Given this list of marker genes Serpinb9, Tmem43, Trim41, Ccl6, Lamp1, C1qb, Zp3r, Tnfrsf1b, H60b, Rab20, Defb5, Triml2 (tripartite motif family-like 2), Lrch4 (NCBI Gene Id 76977), Gm15441, Gimap5, Adam15, Klrc3, Ptger2, Ccdc186, Plaat3 (phospholipase A and acyltransferase 3), Defa37, Slc11a1, Ifit3, Nlrp3, Defa34, Il10ra, Mpo, Calm3, Ddit4, Usp27x, H2-Q7, Cdk6, Lrrc19, Epsti1, Sting1, Traf3, Nlrp4c, Fpr-rs6, Ticam1, Lyzl4, Psma2, Exosc4, Oas1b, Ifi27l2a, Plac8, Cd300lf, Mapkapk3, Klrb1a, Klhl22, Mir30d, Il6, Serpinb9f, Scimp, Stxbp3, Mir30a, Sarm1, Ankrd17 (ankyrin repeat domain 17), Ppp1r15b, Rnf125, Batf2, Trim30b, Ear10, Bcl10, Cd300ld3, Slc22a19, Ddx21, Ifitm6, Defb22, Car3, Cyp3a41a, Bcl2, Ifne, Trim30c, Mir181b-2, Naglu, Gata3, Zdhhc5, Gsdmd, F830016B08Rik, Oxt, Was, Krt6a, Rab11fip5, Nts, Lias, Tac1, Cd86, Cd96, Wfdc11, Mir10a, Gfi1, Lrg1, Cdc42ep4, Adam8, Ccl19-ps6, Slc38a8, Brcc3dc, Rnf19b, Ifnab, Dmbt1 (NCBI Gene Id 270001, deleted in malignant brain tumors 1), 1500002F19Rik, Tifab, Cd4, Mir15b, Ddit3, Laptm5, Igfbpl1, Casp7, Ddx3x, Mir26b, Rbm14, Ifnar1, Mndal, Mptx1, Fosl1, Stmn1, Ppt1, Plscr3, Gsta2, Vtcn1, Ifngr1, Cav1, Vnn1, Vsig4, Rps6ka3, Tfap2a, Ceacam20, Prlr, Mirlet7i, Efnb2, Pcyox1l, Trim15, Spag11b, Ilrun, Selenok, Ugt1a1, Ifna15, Mir467d, C1rl, Hras, Edn1, Xcl1, Rnase12, Mir431 (microRNA 431), Cebpb, Tbkbp1, Gzmb, Vamp4, Mir15a, Calm1, Ly6e, Map2k3, Clec4a2 (C-type lectin domain family 4, member a2), Abl1, Vegfd (NCBI Gene Id 14205), Ywhaz, Heatr9, Uba7, Slc9a9, Paf1, C1qa, Trex1, Reg3b, Clec4d, Fam20a, Mir301, Akap1, Ube2w, Akt1, Plaa, Stap1, Myd88, Car5b, N4bp3, Dusp10, Mettl3, Mt2, Dhx33 (DEAH-box helicase 33), Optn, Ifitm1, Wfdc16, Nlrp9c, Gpatch3, Dab2ip, Sod2, Foxp3, Mfhas1, Mir192, Ncf1, Trim32, Serpinb9g, Cxcl1, Crtam, Tlr5, Syncrip, Grn, Zdhhc3, Abcc1, Trim39, Ulbp1, Lpo, Tlr11, Crk, Smpdl3b, Nmb, Sp110, Nr1i2, Ifi203, Gm5849, Erbin, Nek7, Mir30c-1, Nr1h4, Mir21a, Wfdc9, Casp4, Prg2, Mir30b, Itch, Phb1, Wrnip1, Xrcc5, Rdh18-ps, Ifi204, Saa1, Muc19, Tnnt2, Cpt1a, Ccr1, Ifitm7, Defb48, Tmem106a, Trim43c, Lsm14a, Snx3, Rela, Atp4b, Cd300e, Rab34, Arg1, Mir451a, Rtn4, Rnf39 (NCBI Gene Id 386465), Zfp36, Lrrfip2 (NCBI Gene Id 71268), Vwce (NCBI Gene Id 71768), Adamts5, Trim75, Zdhhc4, Cnr1, Pik3cd, Naip5, Skp2, Il36rn, Chuk, Stxbp2, Coro1a, Cyp3a41b, Defb11, Alpl, Tmf1 (TATA element modulatory factor 1), Gsdma, Trim17, Flnb, Lats2, Ifnl3, Git1, Kif5b, Defb38, Defa30, Gstm3, Mir194-2, Hcfc2, Mir383, Garin5a, Ccl19-ps3, Defb13, Ddx41, Drd2, Hmgcs2, Sftpd, Trim7, Ptger1, Apcs, Gimap3, Irak1, Odc1, Mir323, Gstp1, Smpdl3a, Mir342, Mir7-2, Vim, Rnase2b, Mir484, Tagap, Defb8, Arg2, Mir345, Pdpk1, Calm2, Rnf26rt, Defb34, Atg10, Igkj1, Aurkb, Kpna6, Acod1, Klrk1, Clec4b2, Nod2, Defb3, Smad6, Map3k14, Naip6, Gapdh, Il23a, Klrb1c (NCBI Gene Id 18083), Bspry, Ccr5, Trim30d, Kmo, Il27, Dicer1, Ptgfr, Mir700, Itgax, Mcoln2, Nr1d1, Mus81, Axl, Ncr1, Pdcd4, Tifa, Zfp809, Naip2, Il33, Rnf31, Ccl21f, Fuca2, Map2k7 (mitogen-activated protein kinase kinase 7), Apoe, Polr3h, Klrb1, Slc15a3, Zmpste24, Rnf135, Pcsk1, Ythdf2, Ggt1, Fga, Serpinb9h, Pik3r6, Lag3, Ifna2, Endod1, Myo1c, Gsdma3, Npc2, Eif4e2, G3bp1 (NCBI Gene Id 97760), Cps1, Armc5, Nuggc, Klrg1, Ccl27a, Lats1, Emilin2, Serpinb9b, Pdcd1, Cfd, Gapdh-ps15, Xpr1 (NCBI Gene Id 19775), Clec4a1, Gsdma2, Klrb1f, Ssc5d, Ndufs4, Unc13d, Serpinb9e, Ext1, Trim27, Tlr4, Mavs, Trav10, Rnf185, Casp6, Eif2ak2, Parp1, Gpm6a, Gbp5, Ptpn22, Gata1, Slamf6, Epha2, Il34, Ppl, Lacc1, Dhx9, Ogt, Mptx2, Fpr2, Trem2, Mrc1, Tnfaip8l2, Trim12c, Ccl5, Klrh1, Ccr4, Maob, Trbv13-3, Gm23054, Sfn, Tslp, Trp53, Kif16b (kinesin family member 16B), Bnip3l-ps, Cyp27b1, Cd160, Oasl2 (2'-5' oligoadenylate synthetase-like 2), Zc3hav1, Ear1, Adipoq, Mir27b, Spsb3, Penk, Shc1 (NCBI Gene Id 20416), Irgm2, Smpd1, Ifna5, Tomm70a, Ikzf3, Mir19b-2, Bpi, Ifitm3, Clec5a, Slc19a1, Adamts4, Ednra, Btk, Vil1, Dus2, Atg7, Itgb8, Rnf170, Slamf1, Ifna14, C8a, Ttc39aos1, Pten, Reg3a, Gjb2, Siglecg, Ifi35, Bnip3, Chid1, Clnk, Pak1, Smo, Slamf7, Casp3, Crebbp, Ddx39a, Rigi, Mir511, Appl2, Il12b, Mefv, Slc30a8, Cd6, Selenow, Trim34b, Amy1, Ccl20, Tspan32, Slc46a2, Fap, Cnp, Ifna16, Nbn, Clec4e, Rpsa, Eif2ak3, Nectin2, Xiap, Stx11, Fos, Calhm6, Lsm5, Znrf1, Csf3 (colony stimulating factor 3 (granulocyte)), Mir144 (microRNA 144), Blvra, Mir200b, Pck1, Serpinb9c, Dtx3l (deltex 3-like, E3 ubiquitin ligase, NCBI Gene Id 209200), Cd300lb (NCBI Gene Id 217304), Ins1, Fv1, Smc1a, Polr3k, Cdhr2 (NCBI Gene Id 639588), Casp1 (caspase 1), Palm3, Oas1e, Clec7a, Capn2, Mir106a, Mbl2, Ctr9, Rab2b, Mir215, Wfdc5, Smarca5, Washc4, Rhoa, Trav5-1, Trim38, Wfdc18, Zdhhc9, Ly9, Gfer, Fasl, Sirpa, Ncr3-ps, Gpr15lg, Hyal2, Lgals8, Ttc4, Vapb, Gm4841, Mir103-2, Gpr146, Mir199a-1, Hspb1, Gpam, E2f1, Rab12, Slk (NCBI Gene Id 50513), Mir421, Il4ra, Apobec3, Klk7, Ednrb, Tasl, Sprr2a3, C5ar1, Irf2, Pde4d, Gigyf2, Gbp10, Cx3cr1, Cdk19 (cyclin dependent kinase 19), Stox2, Setd2, Cxadr, Mir409, Trim52, Wdfy1, Malt1, Star, Esr2, Gzma, Klrd1, Pik3cb, Glycam1, Kcnj8, Ighe, Mir202, Duox2, Pglyrp2, Spi1, Ly96, Mir184, Nos3, Myo18a, Polr3g, Nectin4, Gpx2, Klf4, Il4, Trav11, Defb1 (NCBI Gene Id 13214), Tbx21, Hba-a1, Plscr1, Itgav (NCBI Gene Id 76358), Nr2c2, Notch1, Kng2, Znrf4, Oas1g, Tnfaip8, Il15, Slc15a2, Ppnr, Ikbip, Ifngr2, Ifi211, Ifi27l2b, Gm12250, Hsf1, Klri1, Oasl1, Oas2, Bpgm, Pparg, Colec11, Rnasel, Tnfrsf11a, Pycard, Ncbp1, Camp, Cdc73, Gimap6, Pspc1, Sprr2a1, Plscr2, Acp5, Mir223, Kyat1, Adamts9, Mir501, Bid, Anxa1, Ghsr, Trim44, Cfb, Polr3d, Mmp12, Trim14, Nt5c2, Slx4, Trim43b, Klrb1b (killer cell lectin-like receptor subfamily B member 1B), Evl, Casp8, Selenof, C1s1, Thbd, Eme1, Mir155, Defb50, Pde4b, Mir374b, Plscr4, Cxcl14, Zdhhc1, Cd52, Cnr2, F2r, Wipf1, Zc3h12a, Pim2, Sh2d1b1, Prdx3, Mir24-2, Rtp4, Gsdmc4, Akirin2 (akirin 2), Wfdc17 (NCBI Gene Id 100034251), Igkv2-137, Rps15a, Isg20, Isg15, 2410002F23Rik, Zyx, Cd209b, Adamts13 (NCBI Gene Id 279028), B3galt5, Tlr3 (toll-like receptor 3), Mir106b, Shpk, Ulbp3, Ufd1, Tnip3, Defb18, Adgrb1, Il31ra, Shmt2, Hpx, Il17ra, Gm13277, Lgals9, Tap1, Actg1 (NCBI Gene Id 230535), Klhl6, Trim59, Zfp983, Nagk, Fpr-rs4, Ereg, Prdx2, Polr3e, Defa38, Gstcd, Cxcl12, Ccdc92, Wfdc13, Mir425, Lrp8, Ccdc80, Pum1, Nlrp4b, Trim55, Ciita, Nos2, Rac1, C1s2, Tgtp2, Nfkbia, Pstpip1, Mir133b, Brcc3, Prkaa1, Ephb2, Defb35, Ifna4, Tap2, Rps6kb1, C4bp, Csnk1a1, Kynu, Cfp, Aars2, Romo1, Hcst, Tril, Shfl, Ubl7, Usp15, Arl8b, Dtx4, Sgms1, Nfkbil1 (NCBI Gene Id 18038), Wdr83, Mst1r, Defb9, Dhx16, Il10, Mir181a-2, Tirap, Cyp2b10, Cct5, Trim25, Clps, Ccdc88b, Pmaip1, Thrsp (NCBI Gene Id 21835), Ifnz, Gbp7, Bcl3, Ifi44, Ppard, Cotl1, C2, Serpina3n, Nmi, Mef2c, Igha, Cybb, Rasgrp1, Ncf2, Mir500 (NCBI Gene Id 723974), Ywhag, Atg14, Lamp2, Mirlet7a-2, Mill1, Sirt2, Cxcl9, Mif, Gbp3, Esr1, Pdcd1lg2, Fzd5, Pld3, Stab2, Hmgn2, Rag2, Atat1, H2bc12, Stmp1, Defb47, Cdc42ep2, Gsdme, Ptprc, Tlr7, Pld1, Hba-a2, Nlrx1, Nfkbib, Ubqln1, Hamp2, Gsn, Rarres2, Rnase6, Ccl19-ps5, Defa28, Mir126a, Ccl12, Tfeb, Slc10a2, Mir17, Mmrn2, Ipo7, Bank1, Il21, Defa31, Mir27a, Tmem255a, Stxbp1, Gm14335 (predicted gene 14335), Saa3, Arf6, Slfn4, Unc13b, Mir29a, Slc22a21, Mir181a-1, Hnrnpa0, Cyba, Mapk8, Tyk2, Nr4a1, Ifi208, Map4k2, Jagn1, Defb42, Mir217, Vav1, Trim72, Ifna7, Mir7-1, H60c, Ifit1, Nedd4, Gja1, Cptp (ceramide-1-phosphate transfer protein), Tab1, Cd47, BC018473, Trav5d-4, Rrp1b, Ighg2b (immunoglobulin heavy constant gamma 2B), Fcna, Bpifa5, Trim13, Serinc5, Ube2l6, Cd2ap, Trim31, Adar (adenosine deaminase, RNA-specific), Stat2, Ifna6, Rnf5, Ptx3 (pentraxin related gene), Mapk11, Ifit1bl2, Serping1, Cmpk2, Mir122, Wfdc10, Treml4, Itgb6, Ifi206, Nr1h3, Mir194-1, Irak2, Pla2g2a, Cnot7, Defb46, Cadm1, Trafd1, Dcst1, Hadhb, Il36g, Oas3, Rnf26, Bak1, Gbp2b, Mmp7, Resf1, Slc22a13, Fgr, Nlrp1b, Cd209d, Mir26a-2, Acta2, Defb25, St13, Jak2, AA467197, Itln1, Fabp4, Serpinb1a, Trim68, Mir133a-1, Defa20, Gpc3, Abr, Rab27a (NCBI Gene Id 75673), Batf, Trim6, Lrrc15, Nfe2l2, Gjb6, Apoa4, Ifna13, Lyg1, Nqo1, Pum2, Abhd17a, Col6a1, Defa40, Gas2l3, Gpr31b, Clu, Ppm1d, Otud4, Trim10, Mir147, Ifi214, Ifnar2, Pml, Gapdhrt (NCBI Gene Id 218728), Nlrp4f, Mst1, Mir210, Ighg1, Mir29b-2, Cep192 (centrosomal protein 192), Zg16, Cep63, Vgf, Cxcl2, Dhx58 (NCBI Gene Id 93832), Hspd1, Tnfrsf14, Trim54, App, Defb39 (NCBI Gene Id 360214), Vamp8, Trim28, Fer1l6, Sh2d1a, Rpl39, Mir672, Cgas, Gas5, Ifna1, Rara, Ighm (NCBI Gene Id 432703), Rasgrp4, Chga, Epo, Rad50, Capg, Ap1g1, Pgc, Fgg, Defa42, Defa2 (defensin, alpha, 2), Tmem126a, Cd84, Crebzf, N4bp1, Mgst2, Ang, Ccl9 (NCBI Gene Id 20308), Tmem120a, Mr1, Slamf9, Macrod2, Slco1b2, Trav8d-2, Fmr1, Ifit2, Ube2n, Lrat, Tspan6, Ifnb1, Gbp9, Stab1, Mecp2, Gsdmc2, Nlrp10, Usp18, Pisd-ps1, Scn7a, Irgm1, Leap2, Stx8, Mir107, Gzmc (NCBI Gene Id 14940), Tent5a, Hpgd, Pglyrp3, Atad3a, Otud5, Defb15, Mir20a, Gata6, Ipo5, Epg5, Ddx60 (DExD/H box helicase 60), Litaf, Pf4, Hmgn2-ps, Trim56, Naip1, Krt8, Tnip1, Trim26, Wfdc21, Txnip, Smurf1, Gm13271, Tbk1, Ripk3, Dpp4, Dhx15, Yju2b, Ppp1r11, Lcn10, Extl3, Crcp, Lpl, Parg, Defa24, Fbxl2, Pim1, Trav10n, Nmbr, Fer, Il12rb1, Camk2a, Sharpin, Rnase10, Pou2af1, Fgb, Ly86, Oas1f (2'-5' oligoadenylate synthetase 1F), Ankhd1, Letmd1, Calcoco2, Cd8a, Gm11772, Ninj1 (NCBI Gene Id 18081), Psmb9, Igtp, Defb37, Emilin1, G3bp2, Usp29, Reg3g, Zdhhc12, C1rb, Ear6, Csf1, Atg9a, Ndufaf4, Chmp3, Cdc37, Hpgds, Cd24a, Scd1, Tusc2, Nlrp4a (NCBI Gene Id 243880), Gsdmc, D1Pas1, Sp100, Ifih1, Aqp4, Cd37, Prpf8 (NCBI Gene Id 52899), Usp14, Oas1a, Zdhhc18, Gpr108, Traf3ip3, Sfpq (splicing factor proline/glutamine rich (polypyrimidine tract binding protein associated)), Txk, Tnip2, Tgfb1, Ccdc134, Tyro3, Mir140, Oas1d, Stx4a, Lbp, Defb6, Rnf166, Cyp2e1, S100a9, Hamp, Wap, Tlr13, Cd300c, Src, Nexn, Hyal1, Pla2g5, Cd300a (CD300A molecule), Masp1, Daxx, Dach1, Mir486, Mir182, Arf1, Ifit1bl1, Gm24787, Sec14l1, Naaladl2, Senp7, Apob, Marchf2, Mir199a-2, Ythdf3, Rgs1, Ch25h, Il13, Lyar, Mir381, Prkca, Trim65, Nod1, Mark4, Slc12a2, Iigp1c, Slc17a5 (solute carrier family 17 (anion/sugar transporter), member 5), Fau, Rnase13, Phb2, Nlrp4e, Prkd1, Il25, Ncbp3, Mapkbp1, Rel, Defb29, Il1rap, Ido1, Kat5, Ighg2c, Ffar2, Mul1, Irak3, Slfn8, Irf4, Gbp8, Ttll12, Trim30a, Il36b, Trdn, Vps26b, Trav5-4, Cd74, Ccdc47, Trim62, Tyrobp, Rpl13a, Tmem33, Mir205, Klre1, Actr3, Herc6, Trim8, Marco, Ifi213, Sh2d1b2, Matr3 (NCBI Gene Id 69967), Trav3d-3 (NCBI Gene Id 674460), Znfx1, Aqp1, Rab43, Aif1, Lyset, Abi3, Il1a, Lilrb4a, Ubd, Bnip3l (NCBI Gene Id 97931), Mlkl, Pja2, Mir30e, Dclk1, Adh7, Defa5, Becn1, Lgr4, Sbno2, Hspa1b, Tlr2, Cldn1, Lypd8l, Map3k5, Evpl, Rnase11 (ribonuclease, RNase A family, 11 (non-active)), C3, Rpl30, Wipi2, Cd80 (NCBI Gene Id 12519), Traf3ip1, B2m, Ccl8, Ccl21e, Cyp1a1, Pglyrp1, Mir146, Elane, Chrm2, Hmgb3, Nfkb1, Ltf, Ppp6c, Ptpn2, Cd1d1, F2, Gzmn, Pik3r1, P2rx7, Ercc6, Il17f, Tlr1, Lypd8, Tmem229b, Epx, Nppb, Ccl11, Bax, Mov10, Ifnk, Mirlet7d, Mir181c, Uap1, Serpina3f, Dao, Nfkb2, Srebf1, Pnliprp2, Syk, Umod, Xbp1, Ang4, Oas1c, Traf2, Zbp1, Exosc5, Ldoc1, Slc22a5, Ociad2, Agbl4, Nono, Mirlet7b, Krt16, Il1rl2, Fbxo3, Rnaset2a (ribonuclease T2A), Morc3, Mir18, Rab7b, Cd207, Pou2f2, Ifi47, Mgst1, Cd180, Abcc9, Krt1, Tkfc, Ikbke, Cldn2, Il22ra1, Trav8-1, Wfdc6a, Ankrd1, Tspo, Srr, Nck1, Agbl5, Mapk14, Trav3-1, Cr1l, Aim2 (absent in melanoma 2), Ahr, Rab7, Lyplal1, Mirlet7g, Reg3d, Hk1 (NCBI Gene Id 15275), Tlr12, Clec4n, Kctd9, Il1f10, Usp17le (NCBI Gene Id 675388), Pde2a, Il12rb2, Mir26a-1, Ifna11, Wnt5a, Ivns1abp, Trav3-4, Serpine1, Cebpg, Cd274, Sertad3 (NCBI Gene Id 98671), Eprs1, Mbl1, Nfib, Ppp1r14b, Crp, Ccl26, H2-K1, Ly6a, Gper1, Tnfsf8, C1qc, Havcr2, Nlrp9b, Defa3, Mir331, Trim58, Bpifa2 (BPI fold containing family A, member 2), Fcnb, Sash1 (SAM and SH3 domain containing 1), Wdfy4, Lyz2, Rnf144a, Cfh, Mir30c-2, Defa29, Ifi203-ps, Ccl21b, C1qbp, Fcer2a (NCBI Gene Id 194559), Defb36, Rftn1, Ccl27al, Ap3b1, Ins2, Stxbp4, Ptgs2, Lep, Cfhr4, Ifng, Rab11fip2, Defb40, Prdm1, Cx3cl1, Mirlet7a-1, Irf8, Hes1, Bst2 (bone marrow stromal cell antigen 2), Pklr, Peli3, Hnmt, U90926, Cst11, H2-M3, Bpifc, Inpp5d, Mir293, Rnase1, Trav2, Fpr-rs7, Serinc3, Ncl, Spag11a, Apobec1, Defb30, Cd177, C9, Ptafr, Traf6, Ptger3, Trim5, Trim60, Rnase4, Casp9, Trim35, Ticam2, Atl2, Tjp1, Galp, Il17rc, Klrc1, Defa23, Unc93b1, Xrcc6, Flicr, Slc15a4, Polr3b, Cd79b, Mir193a, Adgrl2 (adhesion G protein-coupled receptor L2), Fcer1g, Ddx17, Cubn, Cybc1, Hexim1, Arrb2, Usp50, Gm5431, Mir7b, Myo1f, Il18, Bmp6, Lyz1, Ifna9, Nlrp9a, Zfp683, Trpv4, Trav21-dv12, Ces1g, Ptger4, Ppp2r3c, Clec4b1, Cd1d2, Wfdc15a, Pqbp1, Cxcl15, Ikbkg, Irak4, Mlh1, Defa22, Lalba, Rbbp9, Trib1, Fosl2, Mir16-2, Cxcl5, Slfn2, Pik3ap1, Polr3a, Fkbp5 (NCBI Gene Id 52022), Stat5a, Mir744, Rnase2a, Serpinb9d, Dnaja3, Atl3, Ccr7, Abcf3, Klri2, Smad3, Creb3 (cAMP responsive element binding protein 3), Ang5, Rsad2, Grp, Defb41, Inava, Trac, Snhg1, Padi4, Trim40, Retnlb, Rbm47, Mir148a, Mir146b, Ear14, Fcgr4, Mir291b, Sqstm1, Mx2, Ddx1, Tnfaip3, Ace, Pglyrp4 (peptidoglycan recognition protein 4), Aicda, Mir24-1, Trim29, Mre11a, Upf1, C8g, Jchain, Rbms3, Ppm1b, Wfdc12, Pmp22, Tmem45b, Reg4, Tarbp2, Clpb, Tmeff1, Pvr, Ier3, Mir125a (NCBI Gene Id 387235), Cda, Lyzl6, Bpifa1, Mtdh, Mapk1, C8b, Tigar, Wfdc3, Trim43a, Defa39, Gli2, Relb, Akap12, Ccl19, Rheb, Uri1, Bin1, Ywhae, Hyal3, Gm25038, Mx1, Appl1, Grb2, Il36a (interleukin 36A), Slc7a5, Ifi207, H2bc21, Retnla, Il12a, Cdk4, Gm12185, Clec2d, Mir433, Eppin, Gramd4, Gsta1, Batf3, Nop53, Cd55, Cd2, Pomc, Hdac4, Gsdmc3, Dhx36, Snord3a, Nt5c3, Il1b, Sdhaf4, Traf4, Adam9, Kng1, Mmp8, Cdc42, Ivl, Rab14, Parp9, Ly6g6c (lymphocyte antigen 6 family member G6C), Nos1, Ccl21a, Prkdc, Il7r, Prkcd (NCBI Gene Id 52581), Fadd, Cd226, Mir494, Cldn3, Ifnl2, Defa25, Usp44, Mir598, Fgf15 (NCBI Gene Id 14170), Hsp90aa1, Slpi, Polr3f, Dgkb, Klrc2, Abcb1a, Il27ra, Akap8, Fcgr2b, Riok3, Card9, Mir29b-1, Mir98, Pla2g6, Fbxo9, Trem1, Nlrc3, Ptprs, Ccl17, Hspa8, Ang2, Pla2g10, Eef1g, Ctsg, Mid2, Muc4, Irf1, Flt3, Seh1l, Hmcn1, Cxcl16, Pcbp2, Wfdc2, A2m, Bpifb1, Parp14, Tnfrsf1a, Fgf10, Ppbp, Th, Il17a, Rnaset2b, Defb7, Gbf1, Nkg7 (natural killer cell group 7 sequence), Atf2, Lyst, Zcchc3, Cxcl10, Cd244a, Slc30a1, Rnf34, Ifi205, Prf1, Mmp3, Cactin, Lyz3, Cxcl13, Selenos (selenoprotein S), Spn, Ccl4, Ccl27b (NCBI Gene Id 100504396, C-C motif chemokine ligand 27b), Irf7, Hc, Calr, Irf5, Ifna12, Masp2, Nrros, Ms4a1, Ptpn6, Il2, Gapdhrt2 (glyceraldehyde-3-phosphate dehydrogenase, retrotransposed 2), Cd40 (NCBI Gene Id 98930), Aup1, Trf, Ifi44l (interferon-induced protein 44 like), Bmp2, Ifi209, Gbp2, Trim11 (NCBI Gene Id 94091), Prkce, Ccl3, Gp2, Pla2g2f, Fgl2, Trav8d-1, Trim50, Ptgs2os, Defa35, Cr2, Klk5, Gps2, Gm13283, Vamp3, Ppp2ca, Oprk1, Anxa3, Cyld, Chmp5, Mir142, Msrb1, Mir16-1, Wfs1, Cebpe, Trim12a (tripartite motif-containing 12A), Pde12, Abca1, Gsk3b (NCBI Gene Id 98033), Lyg2, Usp20 (ubiquitin specific peptidase 20), Hspa5, Mpeg1, Lta, Cnpy3, Il10rb, Rnf216, Hmgb1, Hck, Ighg3, Pld4, F2rl1, Mir23b, Clec4a4, Ifitm2, Hp (NCBI Gene Id 15439), Plk5, Hmgb2, Syt11, Fmo1, Havcr1, Tnfsf4, Atg12, Rbck1, Tlr9, Noct, Dapk1, Igkv6-14, Mir1899, Ptpn11, Ccl19-ps4, Nlrp1a, Samhd1, Peli1, Pla2g1b, Bcl2l1, S100a8, Tbxa2r, Colec10 (collectin sub-family member 10), Lgals4, Mir19b-1, Tlr6, Elmod2, Actr2, Sin3a, Wasl, Rnase9, Hrg, Med1, Fpr-rs3, Ube2k, Rab1a, Nfkbiz, Lrrc14, Pabpn1, Enpp1, Gpx4, Srpx, Cflar, Defb33, Mir139, Plekhm2, Ripk2 (NCBI Gene Id 70170), Zbtb1, Jak3, Nploc4, Gpx1, Tab2, Trim3, Smim30, Tnf, Defb2 (defensin beta 2), Mapk3, Igf2, Adam17, Banf1, Il23r, Ccl25, Trim63, Trim69, Fcgr1, Il18rap (interleukin 18 receptor accessory protein), Rab29, Lyn, Rps19, Spon2, Trim34a, Adh5, Il4i1, Cyp3a11, Bcr, Traf3ip2, Chd7, Chil3, Gbp6, Dlec1, Ifit3b, AY761185, Neurl3, Gkn2, Bdkrb1, Irf3, Lcn2, Defb4 (defensin beta 4), Mapkapk2, Trem3, Elp6, Arid5a, Ccl2, Cyp3a25, Grpr, Defa26, Raet1d, Defb10, Nlrp6, Trim61, Upk1b, Nkx2-1, Npy, Mir224, Tarm1 (T cell-interacting, activating receptor on myeloid cells 1), Ecsit (ECSIT signalling integrator), Iigp1, Atg5, Tmco1, Ilf3, C4b, Prdx1, Clec4a3, Cd36, Polr3c, Reg1, Adm, Clec12b, Ppm1e, Flot1, Defa21, Ifnlr1, Otulin, Htra1, Eif2ak4, Mir133a-2, Tut4, Triml1, Mir150, Cd55b, Otop1, Gtf2f1, Jak1, Tab3, Abcd2, Cd40lg, Ddx56, Mtor, Cited1, Alad, Tollip, Cd68, Tgtp1, Tax1bp1, Inhca, Defa17, Pygl, Mecom, Gm22053, Rnf115, Fam3a, Defb21, Cfi, Notch2, Rbpj, Mir103-1, Oas1h, Cxcl11, Defb20, Gbp4, Hif1a (hypoxia inducible factor 1, alpha subunit), Map3k7, Prkra, Scarb1, Defa41, Bcl2l11, Gdi1, Gch1 (GTP cyclohydrolase 1), Nlrc4, 1810065E05Rik, Lrsam1, Trav3-3, Csf1r, Zmynd11 (NCBI Gene Id 66505), Susd4, Ccl1, Ptgir, Pfpl, Ccl21d, H2-T23, Ccl28, Dapk3, Raet1e, Cyrib, Snca, C1ra, Fbh1, Adipor2, Kcnk13, Wfdc15b, Ass1 (argininosuccinate synthetase 1), Vip (NCBI Gene Id 22353), Nras, Defb19, Rb1cc1, Tcf3, Mir200c, Trim21, Ccl22, Ccl24, Slamf8, Ear2, Slfn9, Plpp6, Gm6040, Mir350, Cst9, Hvcn1, Nlrc5, Cstdc2, Scnn1b, Ppp1r14bl (protein phosphatase 1, regulatory inhibitor subunit 14B like), Ces1c, Mir497, Ceacam1 (NCBI Gene Id 26365, CEA cell adhesion molecule 1), Sap30bp, Gm13272, Apol11a, Cd14, Drosha, Stat1, Stat5b, Arhgef2, Lrrd1, Defb12, Colec12, Ccl7, Trav8n-2, 9930111J21Rik1, Slc26a6, Scgb1a1, Ang6, Foxp1, Gm13276, Ren1, Rnf213, Reg2, Klra8, Alpk1, Atg16l1, Ccl19-ps1, Rfpl4, S100a14, Plcg2 (NCBI Gene Id 234779), Usp38 (NCBI Gene Id 74841), Defb43, Defb14, Ufl1, Lgals3, Fbxo38, Gm13275, Cd300c2, Muc5b, Zdhhc11, Tlr8, here is a description of the gene set: Mouse Gene Set: GOBP_RESPONSE_TO_BIOTIC_STIMULUS species: Mus musculus Any process that results in a change in state or activity of a cell or an organism (in terms of movement, secretion, enzyme production, gene expression, etc.) as a result of a biotic stimulus, a stimulus caused or produced by a living organism.